Given this list of marker genes GALK1, here is a description of the gene set: part of: Diseases associated with glycosylation precursor biosynthesis studied in species Homo sapiens Cytosolic galactokinase (GALK1) catalyses the first committed step in the Leloir pathway of galactose metabolism. GALK1 catalyses the phosphorylation of D-galactose (Gal) to form D-galactose 1-phosphate (Gal1P). Defects in GALK1 can cause type II galactosemia (GALCT2; MIM:230200), an autosomal recessive deficiency characterised by congenital cataracts during infancy and presenile cataracts in the adult population. Galactitol accumulation in the lens is the cause of these cataracts. Reactome Pathway: Defective GALK1 causes GALCT2